The following is a description of a gene set: from publication Min L, Isa SA, Fam WN, Sze SK, Beretta O, Mortellaro A, Ruedl C (PMID 22250091) Genes up-regulated in bone marrow-derived dendritic cells: unstimulated versus CSF2 and low dose of 1,3-beta-D-oligoglucan. Human Gene Set: GSE32986_UNSTIM_VS_GMCSF_AND_CURDLAN_LOWDOSE_STIM_DC_UP species: Homo sapiens A simultaneous engagement of different pathogen recognition receptors provides a tailor made adaptive immunity for an efficient defence against distinct pathogens. For example, cross talk of TLR and c-type lectin signalling effectively shapes distinct gene expression patterns by integrating the signals at the level of NF-κB. Here, we extend this principle to a strong synergism between the Dectin-1 agonist, curdlan, and an inflammatory growth factor, GM-CSF. Both together act in synergy in inducing a strong inflammatory signature which converts immature DCs to potent effector DCs. A variety of cytokines (IL-1β, IL-6, TNF-α, IL-2 and IL-12p70), costimulatory molecules (CD80, CD86, CD40 and CD70), chemokines (CxCl1, CxCl2, CxCl3, CCl12, CCl17) as well as receptors and molecules involved in fugal recognition and immunity such as Mincle, Dectin-1, Dectin-2 and Pentraxin 3 are strongly up-regulated in DC treated simultaneously with curdlan and GM-CSF. The synergistic effect of both stimuli resulted in strong IKBα phosphorylation, in its rapid degradation and in enhanced nuclear translocation of all NF-κB subunits. We further identified MAPK ERK, as one possible integration site of both signals, since its phosphorylation was clearly augmented when curdlan was co-applied with GM-CSF. Our data demonstrate that the immunomodulatory activity of curdlan requires an additional signal provided by GM-CSF to successfully initiate a robust β-glucan specific cytokine and chemokine response. The integration of both signals clearly prime and tailor a more effective innate and adaptive response against invading microbes and fungi., and this is the list of marker genes: FAH (NCBI Gene Id 2184), SCML1, PSMD14, FANCG, LSM5 (NCBI Gene Id 95999), UBA2, UBE2MP1, WBP11, MNAT1, VEGFA, APEX2, ALAS1, TMEM154, MTHFD2, ENO2, KMT5A, ETV5, LACTB, MPP1, HAUS2, FERRY3, BRI3BP, SEC13, PFDN2, GMNN, FAM3C, SMAP2, EIF4H, NUP35, RAD18, TIPRL, POLR2H, HSPA14, ICAM1, UBQLN1, ARID3B, IL1RAP, GOT1, DYRK3, REXO5, PSMB3, RRM1, MIS18A, TM6SF1, VDAC1, SLC25A10, TXN, SASS6, PRMT5, TIPIN, SGO2, GNB4, NDUFAB1, DNAJC12, IL1RN, MSRB1 (NCBI Gene Id 51734), CCDC150, SYCE2, TUBG1, NCAPD3, EIF5B, ITPRID2, RRM2, ADRM1, ZEB1, LY86, ACSS2, PRKRA, INTS10, YES1, H3-3B, PIM1, PDE6D, GBE1, CEACAM1, PSMG1, ITPR1, AARS1, ASPHD2, CIAO2B, HK2, EXOSC8, MCM10, HNF1B, RTTN, CHEK2, SRPK1, PGAP1, DRG1, NANP, NUDCD1, UBE2L3, CHD4, MRPL17, BTG3, AP2B1, AK4, NSUN7, RNASEH2A, LRR1, LMNB2, CTPS1, TPI1, ENDOD1, MRPS15, MTHFD1L, WDHD1, STIP1, LRP8, EAF2, CYCS, HSPA4L, GPI, CYC1 (NCBI Gene Id 1537), KIF2C, RHEBL1, NFE2L3, NUP107, VLDLR, EPS8 (NCBI Gene Id 2059), PA2G4 (proliferation-associated 2G4), POLD1, MLF2, SUV39H1, ING2, ALDOC, ZBTB32, CDC25A, TK1, FSCN1, ENO1, DDIT4, NSFL1C (NCBI Gene Id 55968), ANXA3, CCND3, EME1, CCNA1, POLE2, BNIP3 (BCL2 interacting protein 3), CD109, FARSB, ADARB1, PRPSAP2, DPY30, BATF3, SYTL3, ACLY, NDC1, PMAIP1, HSD17B12, SRA1, NUP58, HBEGF, IPO5 (importin 5), RPRD1B, LGALS1, SURF4, ADD2, RFC5, CYTIP, BTBD3, DHRS3, BSPRY, TRAIP, EBP, SNX25, WDR76, CDK6, SCOC, SBF2, GEMIN5, C4orf46, NUF2, SERPINE2, CYB5A, GARS1, CXCL16, PHGDH, C18orf54, GRAMD4, U2AF1, IL18R1, B3GALNT1, ECT2, FAM162A, CA6, STAT3, FRMD4B, ABCA1, CLIC4, ATAD2, ODF2, NARF, CCT4, MAP7D3, PFKFB4, DNA2, SLC7A11, PTPN3